Given this list of marker genes MACROD1 (mono-ADP ribosylhydrolase 1), SSR4, LIME1, OBSCN (NCBI Gene Id 84033), ABCB8, ERGIC3, ZNF688, BST2, NPAS1, MAN1A2, PROC, TKFC, SRM, RAB1A, UAP1, LMNA, PODXL2, LEPROT, TM9SF1, GDE1, TMED9, RCBTB2, COMMD3 (COMM domain containing 3), CD9, RRP8, TP53TG5, CFLAR, SLC38A10, PYCR1, MAST1, MAPK12, NFKBIL1, CFD, CHPF2, YIPF3, DOK3, AIF1, PDIA3, HSPB1, CA5A, HOMER3, COL9A2, TECR, SLC35B1, VKORC1, YIPF5, SERF2, AMACR, INSR, PEX10, TM9SF4, MUC5B, MPC1 (mitochondrial pyruvate carrier 1), MIR22HG, RHEB, GMPPB, FUZ, GM2A, COG7, TIMP2, ABHD14A, IGLJ3, NDUFA4L2, CUX1, FUCA1, FER1L4, LAP3, MGAT1, PAM, GMPPA, GNB3, SLC3A2, SEC23B, TMED5, CRABP2 (NCBI Gene Id 1382), IGKV3-20, UROD, GAS6, QPCT, EHD4, FKBP2, DHRS7, SRPRB, BUD23, DAD1, MCF2L-AS1, AKR1A1, TMCO1, SCAMP5, MRPS31, CYB5R1, FAH, PIGT, FNDC3B, TNFRSF4, YIPF2 (Yip1 domain family member 2), SLC39A7, EXT1, AGA, ZNF706, SIL1, PDXK, IGLL1, UBA5, LEPROTL1, AMPD1, YIF1A, ELL2, HEXB, TPM4, ARHGEF16, TIMM17B, REEP5, TMBIM6, TAPBPL, GNRH2, BSCL2, TREM2, RRAD (NCBI Gene Id 6236), RAB9A, TKTL1, SPAG4, CCNP, NENF, FICD, CREB3L2, GP1BB, IGLV4-60, PHKG1, MAPKAPK5-AS1, ARSA, ABHD8 (abhydrolase domain containing 8), PDIA4, CLCC1, RRBP1, AK1, TMEM115, CELA2B, SMPDL3B, NEU1, PMM2, DSTN, TUT1, RPL3L, RRP12, ADA2, SRPRA, SIGLEC9, COPE, CITED2, PHOX2A, KDELR3, RALY, RAPGEF2, B4GALT3, CAV1, IDH2, GPR37L1, TRIP6, FUT8, ANG, ARFGAP3, SLC7A5, ABCB9, CTSW, CDK5, CLIC4, WIPI1, IFNAR2, ADAP1, TM9SF2, ACADVL, NET1, TOP6BL, COPS6, PFKFB1, VPS37B, SURF1, MVD, HSD17B8, UCN, LSR, HSF1, CD300A, NDUFB7, EMC7, ST6GALNAC4, NTN1, MORF4L2, CNPY2, PPY, GADD45GIP1, SPCS3, PRCP, DUSP5, MPST, SEC24A, SSR2, DNAJC1, here is a description of the gene set: from publication Abbas AR, Baldwin D, Ma Y, Ouyang W, Gurney A, Martin F, Fong S, van Lookeren Campagne M, Godowski P, Williams PM, Chan AC, Clark HF (PMID 15789058) studied in species Homo sapiens Immune cell-specific expression is one indication of the importance of a gene's role in the immune response. In order to identify such patterns, we set out to broadly profile gene expression in a variety of immune cells. Genes down-regulated in comparison of memory IgM B cells versus plasma cells from bone marrow and blood. Human Gene Set: GSE22886_IGM_MEMORY_BCELL_VS_BM_PLASMA_CELL_DN